The following is a description of a gene set: This event has been computationally inferred from an event that has been demonstrated in another species.<p>The inference is based on the homology mapping from PANTHER. Briefly, reactions for which all involved PhysicalEntities (in input, output and catalyst) have a mapped orthologue/paralogue (for complexes at least 75% of components must have a mapping) are inferred to the other species. part of: MAPK targets/ Nuclear events mediated by MAP kinases electronically inferred by orthology from the curated human pathway studied in species Mus musculus Reactome Pathway: Activation of the AP-1 family of transcription factors, and this is the list of marker genes: Mapk14, Mapk3, Mapk11, Mapk9 (mitogen-activated protein kinase 9), Fos, Jun, Mapk8